Given this list of marker genes MAPK1, NOD1, IKBKG (NCBI Gene Id 8517), FGG, IRAK4, JUN, MAP2K3, MEF2C, NFKB1, DUSP4, NFKB2, MAPK9, PPP2CB, CD36, PPP2R5D, RPS6KA5, MAP2K1, NLRX1, TAB3, USP14, N4BP1, S100A1, RIPK2, ALPK1, MAPKAPK2, TLR4, SFTPA1, PPP2R1A, RPS6KA1, USP18, DUSP3, BTK, TIRAP, DUSP6, TLR1, LRRC14, MEF2A, MAP2K6, FOS, S100A9, RPS27A, SKP1 (S-phase kinase associated protein 1), CREB1, TLR2, NFKBIA, VRK3, HMGB1, ATF2, IKBKB, CASP8, SFTPD, CUL1, UBA52, TAB2, TRAF2, FGB, DUSP7, N, MAPK10, FBXW11, RELA, NOD2, S100A12, MYD88, CD14, TP53, MAP3K8, MAPK3 (mitogen-activated protein kinase 3), IKBIP, porB, TNIP2, NKIRAS2, MAP2K4, NFKBIB, TIFA, BTRC, MAP3K1, MAPK7, SAA1, MAPKAPK3, MAPK14, PELI3, PELI2, FGA, SIGIRR, PELI1, AGER, RPS6KA2, UBE2V1, S100A8, UBE2N (ubiquitin conjugating enzyme E2 N), LY96, IRAK3, RPS6KA3, NKIRAS1, ATF1, MAPK11, UBB, ELK1, mip, TRAF6, IRAK1, SFTPA2, SOCS1, UBC, PPP2R1B, TAB1, TLR6, MAPK8, IRAK2, S100B, ECSIT, MAP3K7, MAP2K7, APP, CHUK, NLRC5, PPP2CA, here is a description of the gene set: Reactome Pathway: Toll Like Receptor 2 (TLR2) Cascade TLR2 is involved in recognition of peptidoglycan from gram-positive bacteria, bacterial lipoproteins, mycoplasma lipoprotein and mycobacterial products. It is quite possible that recognition of at least some other TLR2 ligands may be assisted by additional accessory proteins, particularly in association with TLR1 or TLR6. TLR2 is expressed constitutively on macrophages, dendritic cells, and B cells, and can be induced in some other cell types, including epithelial cells. TLR1 and TLR6, on the other hand, are expressed almost ubiquitously. TLR2 may be a sensor and inductor of specific defense processes, including oxidative stress and cellular necrosis initially spurred by microbial compounds. studied in species Homo sapiens part of: Toll-like Receptor Cascades